The following is a description of a gene set: studied in species Homo sapiens Genes having at least one occurrence of the motif MGTTACYAGGCAAM in the regions spanning 4 kb centered on their transcription starting sites. This matches the RFX1 transcription factor binding site V$EFC_Q6 (v7.4 TRANSFAC). Human Gene Set: EFC_Q6, and this is the list of marker genes: PRRT1, EBNA1BP2, IFT46, OMA1, CD68, PAX6, CDK19, TTC16, GBF1, LRMDA, C12orf57, MET, NRGN, THNSL1, WHRN, BMP6, HNRNPF, AMHR2, HOXC6, PTCH1, HMGN3, BMPR2, ELAVL4, CEP41, RREB1, STRN4, PDE1A, FOSB, ZNF710, BCL6, SLC7A1, CCDC22, STMN4, ARL4A, HOXA3, MT4, TCTN3, MIEF2, SYT6, CARS1, SIN3A, BMP5, CRIP2, ZC3H11A, ANKRD45, IRS2, PDZD4, TNS2, OTUD7B (OTU deubiquitinase 7B), HOXA4, WARS2, CFAP57, CCDC13, FKRP, PPT2, LRRC8A, KCNA2, SCNN1A, FLRT1, CDK20, PPIL4 (NCBI Gene Id 92943), MITF, FOXD3, KLF3-AS1, XPNPEP3, FUZ (fuzzy planar cell polarity protein), SLC39A12, GPR119, VEGFA, FHIP1B, RNF25, HOXB6, LMO3, VSIG1, ZC4H2, CCND2 (NCBI Gene Id 894), EBF2, SNPH, BARHL2, SLC22A8, INSRR, NEUROD2, CCDC6, FAM131A, SEMA5B, FERD3L, SASH1, ELAPOR1, FAF1, HOXC4, NCOA5, C2CD2L, TCEAL1, RAD9A, BNC2, MORF4L2, ACER3, DIPK2B, SMAP2, BTG4, RNF141, ENKUR, MIR22HG, HAMP, HOXD4, ALMS1, YWHAE, GALNT14, PAK6, GPR22, PARP6, NOS1, SOX2, B3GALT2, QRICH1, MAGED1, DPYSL5, DPY30, ZMYND8, ITGB8, SERPINB3, ARPC5, TAOK2, SLK, HOXA10, KDM3A, BTRC, HNRNPH2 (heterogeneous nuclear ribonucleoprotein H2), UBE2L3, CELSR2, DDX17, ZNF407, TDRD7, NEK2, GGN, PCYT1A, HELZ2, DIO3, TRIM39, CITED2, DYDC2, SOBP, VIT, GTF3C1, RUSC1-AS1, ETS2, PTPN22, CAMK2A, PSD, PDE6D, PDCL2, CAMKV, RPL32, BTBD3, PRRX1, SLC17A6, KCNQ1DN, MYCLP1, TM9SF1, ST13, NDUFS4 (NADH:ubiquinone oxidoreductase subunit S4), PPME1, PHTF1, BLOC1S2, COPS5, MRPL32, DDX31, KLHL1 (NCBI Gene Id 57626), FXYD6, CACNA1D, PPP3CB, PSMF1, BDNF, EN2, MSMB, HES1, OSR2, REM2, GPR162 (G protein-coupled receptor 162), ASCL4 (achaete-scute family bHLH transcription factor 4), SECISBP2L, TMEM209, GRIN3A, CACNA2D3, PNKD, LSM6, RRM1, MED25, AKAP1, CEP95, KLF3, TNKS1BP1, NONO, KRT79, DMD, COQ8B, PSMA2, ELMOD1, MEIS2, YWHAG, FGF9, THRA, IGSF8, PCYT1B, APOBEC4, SLC4A2, CDX4, RPP21, MAP1A, FAM167A (family with sequence similarity 167 member A), PIK3R5, DHX30, TBPL1, ARMC3, SENP1, KCNA1, STK36, SHANK1, BCL2L2, HOXA11 (homeobox A11), EYA1, C10orf53, LINC01597, PCDH17, UBL4B, KIRREL2, FIBCD1, ROBO3, GLA, NTRK1, GDPD2, MTA2, JADE2, KCNN3, RUNX1T1, NLGN3, CBX6, NPAS3, WDR81, GRIK5, TBC1D16, TP53BP1, STAT5B, KCNRG, RFX4, SELENOF, CCDC60, AP1M1, ARID1A, BCL2L1, KCNE1, EFNB3, SELENOO, PDZRN4, ORAI3, TSC22D1, LDB2, USP12, ZFP36L1, GTF3C4, CYP26B1, HM13, AGO1, ABI2, PRDM12, HS2ST1, GOLPH3L, RGL1, DNAH9, SIX1, NUDC, CD69, ZBTB48, PACSIN2 (protein kinase C and casein kinase substrate in neurons 2), EDC4, XPOT